The following is a description of a gene set: Mouse Gene Set: MIR_137_3P species: Mus musculus Genes predicted to be targets of miRBase v22 microRNA mmu_miR_137_3p in miRDB v6.0 with MirTarget v4 prediction scores > 80 (high confidence targets). from publication Chen Y, Wang X (PMID 31504780), and this is the list of marker genes: Armc1, Col19a1, Runx2, Esrra, Luzp2, Mettl9, Fam76b, Bcorl1, Grip1, Lgi3, Swt1, Chst10, Syndig1, Dip2c, Fgf7, Fgf16, Mboat2, Aggf1, Rhox2b, Septin3, Atxn1l, Gria4, Stk38, Raver2, Mbtps2, Insyn2b, Vax1, Herpud2, Rnf138, Grm5, Ybx1, Snx25, Baz1a, Myo1d, Pias2, Slc35e2, Mgll, Syt1, Mxd1, Cybrd1, Arf4, Tlcd4, Sez6l2, Tsn, Pptc7, Scarb1, Paxbp1, Rwdd4a, Nabp1, Kdm5b, Fam210b, Cd2ap, Cacna1h, Ric8b, Gm715, Asb13, Zfp804a, Ctdsp2, Fmnl2, Tdrd7, Jmy, Efr3a, Cast, Ankrd33b, Fkbp4, Pgm2, Sptbn4, Epc2, Anapc13, Wwp2, Rsbn1, Marchf8, Egr2, Ulk2, Ccn4, Oxsr1, Vwa5b2, Cdc37l1, Adamts3, Mbnl2, Stt3b, Zc3h6, Slc43a2, Atp10a, Plcb1, Clec16a, Zc3h3, Jade1, Arhgef38, Whamm, Dsp, Stac, Gltp, Atat1, Chia1, Dexi, Pdcd6, Stk11, Spata16, Npc1, Clxn, Rgs6, Smurf2, Slc6a1, Zfp36l2, Wbp1l, Zpr1, Kcnc3, Dr1, Cimip3, Zfp523, Arhgap44, Mef2a, Kat2b, Traf3, Lmtk2, Calcoco1, Ccdc38, Abhd6, Slc6a8, Arf6, Prdm1, Pramel20, Fgf11, Hmgn3, Tpcn1, Lemd3, Arid4b (AT-rich interaction domain 4B), Pramel16, Nat8l, Daam1, Mapk10, Slc4a7, Rhox12, Tsnax, Mapkapk2, Ppargc1a, Col10a1, Rbpj, Unc79, BC051019, Limch1, Acrv1, Polr2c, Fnip1, Limd1, Naa15, Nck1, Tjp2, Lrrc10b, Gpr137b, Sgpl1, Dmrt3, Sox6, Tcf4, Sipa1l2, Ark2n, Gfpt1, Tbx18, Pitpna, Dmrt2, Rictor, Rrm2b, Cxxc4, Pctp, Rnf38, Rhox2f, Rhox6, Lzts3, Fgf9 (NCBI Gene Id 252883), Zbtb21, Furin, St18, Zfp217, Neurod4, Msrb3, Rmnd5a, B3galt2, Mpc1 (NCBI Gene Id 70697), Nkapd1, Hycc2, Gxylt2, Gtf2a1, Phtf2, Sptlc1, Nckap5, Nrep, Ssbp2, Fstl1, Arhgef18, Trim33, Zbtb44, Tmem229b, Hlf, Ankrd12, Ago1, Akr1b10, Ptpn5, Pkd2l1, Sv2a, Nrg3, Castor2, Hic1 (NCBI Gene Id 15248), Hsd17b13, Dcdc2a, Plxdc2, Zfp710, Pde4a, Efcab14, Htr2c, Usp24, Zfp326, Dtx2, Sash3, Erbin, Tcf12, Adcy2 (adenylate cyclase 2), Padi2, Chd9, Tfap2a, Rhox2e, Grb7, Gpcpd1, Nfatc2, Tbc1d31, Cul3, Rragd, Appl2, Cttnbp2nl, Synj1 (NCBI Gene Id 77939), Ccz1, Ankrd28, Slc12a6, Zfp143, Ahcyl2, Rhox2c, Plk2, Rrbp1, Rreb1, Caln1, D17H6S53E, Fam117b, Msi2, Nbeal2, Mid2, Serp1, Ncoa2, Gramd4, Slc46a3, Car7, Slc6a14, Ugcg, AI593442, Lingo2, Ss18, Kit, Zcchc2, Sik1, Cpq, Ap3s1, Cdh12, Cyb5r4, Clec5a, Glis2, Slc6a9, Tent4a, Tbc1d12, Tars2, Gucy1a2, Snrk, Bcor, Ybx3, Slc35a5 (NCBI Gene Id 74102), Dsg1c, Prkab1, Slc8a1, Slc12a2 (NCBI Gene Id 20496), Vegfc, Atpaf1, Khdc4, Tmem33, Fndc5, Golga7, Ncoa3, Necab3, Lmbr1l, Scn8a, Gramd2b, Tmem218, Syncrip, Igfbp5, Cables2, Fhip2b, Ptgfrn, Rcor2, Pradc1, Zmym2, Psmc6, Map3k20, Rora, Epha8, Afm, Osbp2, Mitf, Kmt2a, Map3k14, Cpxcr1, Akr1b7 (NCBI Gene Id 11997), Gjb3 (NCBI Gene Id 28026), Grk6, Fat3, Fam168a, Glce, Pdlim3, Asph, Zzef1, Vash2, Slc1a5 (solute carrier family 1 (neutral amino acid transporter), member 5), Neurod1, Rassf4, Hnrnpdl, Ap1s3, Ppp4r2, Nkain1, Kdm1a, Ptchd4, Sh3pxd2b, Cxadr, Ptpn2, Maml1 (NCBI Gene Id 211871), Kcnab3, Mab21l1, B4galt5, Gad2, Prr16, Aida, Snx14, Elovl2, Scrt2, Ranbp9, Nfyc, C1qtnf12, Clic5, Prkar2b, Plekha7, Ccdc90b, Tbc1d1, Cacna1g, Rhobtb1, Ubxn2a, Hcrt, Inpp5a, Srsf6, Ube2g1, Dipk2a, Map4k2, Rell1 (NCBI Gene Id 212629), Rbm27 (NCBI Gene Id 225432), Ski, Src, Vma21, Ccng2, Rap2c, Nxt2, Leng1, Ube2k, Shroom2, Zbtb7a, Ankrd13a, Oxr1, Klf12, Hip1r, Sgcg, Zfp148, Slc35a1, Ube3c, Lurap1l, Mlc1, Ms4a7, Chic2, Epha7, Otud7b, Dusp4, Slc45a3, Strbp, Ezh2, Nfasc, Nfe2l2, St13, Pip4p2, Styx, Btaf1, Pla2g15, Tsc22d2, Cnep1r1, Csnk1g3, Cysrt1, Pramel31, Bysl, Tjp1, Dag1 (dystroglycan 1), Slc30a4, Gnat1, Pxn, Fam222b, St3gal3, Nf1, Kcnmb2, Mpp1, Pakap, Slc35a4, Rbm41, Ncln, Fthl17a, Fgl2, Neto1, Stk40, Rnf4, Fam78a